Given this list of marker genes NEU3, MIR298, MTHFD1, PRNP, HAL, ERO1B, SUCLG1, CLU, HAP1, CTSG, AGMAT, MIR127, ACSM5, MGST2, LRP4, ACSM3 (NCBI Gene Id 6296), GSTT2, SPHK1, GLB1, HTD2, PCSK7, SPHK2, EFNA1, PPT1, PM20D2, CMA1, CERS1, NPL, PMVK, PEMT, CERK, PDK1, GSAP, PLAAT1, SLC25A2, MTOR, MVD, APEH, GSTK1, FH (fumarate hydratase), MBOAT4, APOE, SHMT1, ACOT2, CTSZ, ACSL5, GGTA1, P2RX1, SMPD4 (sphingomyelin phosphodiesterase 4), DGAT2, NSMAF, BAAT, ASNS, PANK4, GSK3A, PIN1, SLC25A42, SUCLA2, PDHX, TLCD3B, DHFR, MEP1A, AGK, OSBP, DCAKD, SIRT3, NAGK, CLN6, PAQR4, MCEE, HEXA, AMDHD2, SLC35A1, OTC, HMGCS2, TPK1, GGA3 (golgi associated, gamma adaptin ear containing, ARF binding protein 3), CYP4F22, TDO2, GGT5, ACOT8 (acyl-CoA thioesterase 8), ACACB, PGK1, PCSK5, BLOC1S6, GCDH, GLYAT, ST3GAL2, MMUT, MIR361, CCN1, SMPD1, UROC1, CMAS, GNE (glucosamine (UDP-N-acetyl)-2-epimerase/N-acetylmannosamine kinase), DHFRP1, PLAAT2, ACOT4, PDK4, NT5C2, ACSF2, B3GALT4, CTNS, CPS1, FAR1, GSTA1, DIP2A, PLPP3, CPA3, PLA2G15, DGAT1, SPTSSB, PPCS, NR1H4, ST3GAL3, DPEP2 (dipeptidase 2), AADAT, ORMDL3, LDLR, ELOVL2, CYP2C9, GSTT1, NANP, FUT3, MIR29B1, MTHFS, GLA, SORL1, BCKDK, RPTOR, PLPP2, MLYCD, FAR2, CD36, HACD2, ACSM4, ACSM2B, PLA2G6, AASS (aminoadipate-semialdehyde synthase), IGF1, ACOT11, CERS6, RTN4, GPX1 (NCBI Gene Id 2876), MCCC1, RTN3, ALDH1L2, GGTLC3, ASL, ACOT12 (NCBI Gene Id 134526), ACAT1, GAL3ST1, ZNF750, MECR, ACSL6, NFE2L1, SLC27A2, GDA, ASS1, GSTA2, REN, PDK3, GSTM2, CORIN, GSTP1, PLAAT3, DLAT, TNF, CARNMT1, SLC7A11, ABCA7, GGT6, YIPF5, PLA2G7, DPP4, CARNS1, UGCG, ACOT6, ACSS1, B4GALT6, ALOXE3, IDE, MTHFD2L, HSD17B12, GCLC, HID1, ABCD1, CERT1, GSTA4, BTD, ACER2, HPGDS, GSTO2, SGMS1, ELOVL6, BIN1, GSTT4 (glutathione S-transferase theta 4), MIR339, SLC16A12, SMPDL3A, PCSK2, UGT8, ASMT, SLC25A32, CTSL (NCBI Gene Id 1514), NAT8B, ACOT1, OGDH, CERS5, PLAAT4 (NCBI Gene Id 5920), ACSBG2, PICALM, ACOT9, MIR29A, NIT1, B4GALT5, GNPDA2, MLST8, ALOX12B, B4GALNT1, NFE2L2, PANK3, ST3GAL1, ST3GAL5, NUDT19, P4HB, P2RX7, OXSM, MIR206, LRRTM3, SUCLG2, SLC2A13 (NCBI Gene Id 114134), ADAM10, ACER3, ELOVL4, GSTA3, PLA2G4E, CERS4, NCSTN, VNN2, EPHA4, CBR4, ENPEP, SMPD3, SMPDL3B, GSTM3, MIR29C, NTRK2 (NCBI Gene Id 4915), ABCA12, ACSBG1, CPN1, RTN1, PCSK4 (NCBI Gene Id 54760), FURIN, GSTM4, PIPOX, XDH, ABCA2, ITGB8, DNPH1, ASAH1, GSTM5, NAGS, GSS, TP53, PDHB, ORMDL2 (NCBI Gene Id 94102), NANS, SP1, ASAH2B, ABHD4, ST8SIA3, PREP, CROT, MIR15A, ST6GALNAC4, ECE2, MIR455, SLC25A16, ST6GALNAC6, FASN (NCBI Gene Id 2194), ROCK1, ATF4, CTSH (cathepsin H), SLC1A1, ACACA, GALC, SPON1, PM20D1, SPTLC2, SPTSSA, BECN1, B3GALT1, ATP6AP2, MPC2, PSENEN, PCSK1N, ABCG1, CHAC2, GSR, PANK1, NUDT7 (nudix hydrolase 7), ACSL1, DHFR2, GBA3, NUDT8, AAAS, B3GALT2, DPEP1, MGAT3, HLCS, SGPL1, CEBPA, LRP1, CPE, RELA, GM2A, PCSK1, PLAAT5 (phospholipase A and acyltransferase 5), ACSF3, ACE2, XPNPEP1, SGMS2, TECR, RENBP, CEL, NT5C1A, GGT2P, CERS3, SLC30A8, AMDHD1, ACSL3, MIR186, GLRX2, ELOVL7, SLC25A15, TMED10, ENSG00000293349, ACSM6, ACE, FUT5, CLN8, ACSM2A, ORMDL1, MIR103A1, HEXB, CHAC1 (ChaC glutathione specific gamma-glutamylcyclotransferase 1), PDHA1, LCT, DEGS2, GBA1, ST6GAL1, CSNK1E, GGT7, PRKCD, MMACHC, ACSL4, ALDOB, MIR15B, ECE1, FPGS, SLC1A2, NAPEPLD, GGTLC2, MVK, B4GALT3, MTHFD2, ACLY, PDHA2, APH1B, DEGS1, BCHE, OPLAH, BACE2, FUT7, C20orf173, PCSK6, PLPP1, SCARB2, PRKAA1, SLC5A6, MTRR, ST8SIA4, SNCA, COASY, MME, GPAT4, PNP, NDP, GGT1, PANK2, ROCK2, DLST, FTCD, FA2H, FITM2, CERS2, PSEN2, ELOVL3, NAGLU, SLC30A5, DYRK1A, ARL6IP5, GNPDA1 (NCBI Gene Id 9930), ALLC, SLC46A1 (NCBI Gene Id 113235), GSTT2B, ABCA8, CHRNA7, DLD, GGTLC1, APOA1, ELOVL5, APH1A, GCLM, HAGH, SCG5, NEU1, AASDHPPT, GGT3P, TM9SF2, TREM2, ACOT7, TIGAR, AANAT, MIR195, ST8SIA2, NEU4, CASP3 (NCBI Gene Id 836), ACSM1, HTRA2, SMPD2, ACER1, ANPEP, VAPA, ETHE1, PAM, MIR16-1, ST6GALNAC5, ASAH2, ELOVL1, URAD, PRCP, DISP1, SLC19A1, PPCDC, TNFRSF1A, MIR153-1, GBA2, ACSS2, HMGCR, PPT2, GPAM, GSTZ1, ST8SIA6, MCCC2, SPTLC1, BACE1, GSTM1, ARG2, HMGCS1, SAMD8, SOD2, PDK2, PSEN1, FOLR1, GSTA5, RTN2, VNN1, IFNG, ENPP7, GLO1, NAAA, HACD1, ST6GALNAC3, MIR24-1, ARG1, NT5C, SOD1, NEU2, THEM5, G6PD, GSTO1, B4GALT4, FUT6, IDH1, PNPLA1, SPTLC3, ADA (adenosine deaminase), NNMT, HSD17B4, NAT8, IFNGR1, here is a description of the gene set: The chemical reactions and pathways involving an amide, any derivative of an oxoacid in which an acidic hydroxy group has been replaced by an amino or substituted amino group, as carried out by individual cells. studied in species Homo sapiens Human Gene Set: GOBP_AMIDE_METABOLIC_PROCESS